Given this list of marker genes PABPC4 (NCBI Gene Id 8761), KDR (kinase insert domain receptor), SERPINB1, AMBP, CADPS, APOH, MRPL37, PNKD, MAP3K12, TRIB3, STX7, NEK4, PFKFB3, HK1, COQ5, SNX2, KMT2E (NCBI Gene Id 84147), ING1, HNRNPA3, DUSP1, FRRS1, GALK1, SERTAD1, KRT2, OGA, ZFAND5, CNDP2, ATP5F1C, HM13, ETS2, MAGEL2, RHBDL3, MBD2, SPRYD4 (NCBI Gene Id 283377), LYN, NAB2, LCK, TRAF5, RSRP1, HBS1L, PSMD13, TIMP3, IER2, ITGB5, PIPOX, PTH, ZNF740 (NCBI Gene Id 283337), TCEA3, RBMS2, PHTF1, KIF4A, OCM2, CTNNB1, FAM114A2 (family with sequence similarity 114 member A2), MMP7, SEMA4F, KRT71, IL1RN, LITAF, CASP4 (caspase 4), PNRC1, MARCKS, DAB2, GLIPR2, DKK2, TMEM176B, RFC1, HOXB7, DDIT3, SPAG5, S100A8, IL5, SKP1, C2CD3, NTF3, PHLDA1, CD38, SCAF11, SNX1, DDX19B, TSPAN33, CASP7, OTUD4, MAP6, VIPR1, SAA2, NCKAP1, TAF1D, CLCN5 (chloride voltage-gated channel 5), ACTC1, SARS1, SNX5 (sorting nexin 5), SLC20A1, SOAT2, TBL1XR1, ITGB1BP1, EWSR1, HLX, ZHX1, CDH1, NDRG3, PKM, MCOLN2, ACKR4, LDHA, WDFY2, SEMA6B, CCN2, KLF10, TRIM13, EMP1, DECR1, ALDOAP2, SLC10A3 (solute carrier family 10 member 3), ARG2, NXT1, SPDEF, BATF, ATP11A, WDR82, FGA, KRT36, GLDC, DNMT1, CNN3, SPCS1, SYP, GFAP (glial fibrillary acidic protein), LCN2, CSF3, CNOT6L, SMC2, UTY, USP38, RCL1, RBPJ, E2F1, CCND1, THY1, DUSP8, PPP2R1B, FGF7, CKS1B, PTPRG, MRE11, PHF13, ISLR, PFDN1, GMPPB, MAP3K8, CD93, HSBP1, IL10, FPR2, DUSP12, SLC22A18, GJA1, PNPO, TAX1BP1, STX12, MYT1L, SPATA13, FAM162A, CBX6, CD79A, IREB2, CP, FHL1, CD53, BCAP31, IFNAR2, PIM3, BZW2, SOWAHA, SLC12A7, NUDCD2, CTF1, CD86, TUBA4A, IL6ST, C2CD2, C1QBP, TSNAX, DDX52, EMB, AIF1, SUPT4H1, PHF7, LAMP2, TFPT, HSD17B10, SLC16A1, DHH, RHOQ, EDNRB, NDUFA2, CXCL14 (C-X-C motif chemokine ligand 14), MYL3, FYTTD1, ANKZF1, here is a description of the gene set: from publication Yosef N, Shalek AK, Gaublomme JT, Jin H, Lee Y, Awasthi A, Wu C, Karwacz K, Xiao S, Jorgolli M, Gennert D, Satija R, Shakya A, Lu DY, Trombetta JJ, Pillai MR, Ratcliffe PJ, Coleman ML, Bix M, Tantin D, Park H, Kuchroo VK, Regev A (PMID 23467089) Despite their enormous importance, the molecular circuits that control the differentiation of Th17 cells remain largely unknown. Recent studies have reconstructed regulatory networks in mammalian cells, but have focused on short-term responses and relied on perturbation approaches that cannot be applied to primary T cells. Here, we develop a systematic strategy – combining transcriptional profiling at high temporal resolution, novel computational algorithms, and innovative nanowire-based tools for performing gene perturbations in primary T cells – to derive and experimentally validate a temporal model of the dynamic regulatory network that controls Th17 differentiation. The network is arranged into two self-reinforcing and mutually antagonistic modules that either suppress or promote Th17 differentiation. The two modules contain 12 novel regulators with no previous implication in Th17 differentiation, which may be essential to maintain the appropriate balance of Th17 and other CD4+ T cell subsets. Overall, our study identifies and validates 39 regulatory factors that are embedded within a comprehensive temporal network and identifies novel drug targets and organizational principles for the differentiation of Th17 cells. species: Homo sapiens Human Gene Set: GSE43955_TH0_VS_TGFB_IL6_TH17_ACT_CD4_TCELL_10H_UP Genes up-regulated in CD4 T helper cells (10h): Th0 versus TGFB1 and IL6.